The following is a description of a gene set: Activation of Kir 3 channels occurs after binding of G beta gamma subunits of GPCR. Activation of Kir3/GIRK leads to K+ efflux. The dissociation of GPCR into G alpha and G beta gamma subunits is activated by the activation of GABA B receptor by GABA binding. part of: G protein gated Potassium channels species: Homo sapiens Reactome Pathway: Activation of G protein gated Potassium channels, and this is the list of marker genes: KCNJ2, GNB3, GNG13, GNG11 (NCBI Gene Id 2791), GNGT2, KCNJ9, KCNJ12, GNGT1, GNB4, GNB5, KCNJ10 (NCBI Gene Id 3766), GNG4, GNG8, GNB2, GNG7, GNG3, KCNJ16, KCNJ4, KCNJ5, GNG5, KCNJ6, GNG10, GNB1, KCNJ15, GNG2, GABBR1, KCNJ3, GNG12, GABBR2